The following is a description of a gene set: Mouse Gene Set: GOBP_RESPONSE_TO_HYDROGEN_SULFIDE species: Mus musculus Any process that results in a change in state or activity of a cell or an organism (in terms of movement, secretion, enzyme production, gene expression, etc.) as a result of a hydrogen sulfide stimulus., and this is the list of marker genes: Pink1, Abcc9, Kdr, Nqo1, Prkn